Given this list of marker genes ARRDC4, INPP4B, MFAP1, TOR4A, RFXANK, TEX35, ABCC4, PRDM16, PSME2, USP18, TIGD2, PEX7, ARMC7, DMD, C16orf54, CD82, F2R, RLIG1, IFT57, RIC8A, TRAF5, COL1A2, AVEN, CA3, VAMP8, UFSP1, CHMP2A, STAB1, NOTCH1, LAMA5, PTPN9, CRYL1, SOCS2, CST7, LPCAT1, NUDT18, FARP2, CASTOR1, ZC2HC1A, RNF216, CHAC1, NENF, EEF1AKMT1, TM7SF3, RFTN2, ELL2, HSD17B11, PTF1A, GPR15, TSACC, STPG1, CLDN12, PRG4, STING1, NUCB2, EXOC3, KLK8 (kallikrein related peptidase 8), ITGAE, GRN, NFE2L1, ECH1, TESC, IRAK4, NFIX, SLX9, SEMA4B, SYT11, VAMP5, NT5E, ATXN1, KMT5A, TOMM40L, NAB1, WWP1, HOMER1, ALDH2, RNH1, MVB12A, IKZF5, ZDHHC2, ATM, TBC1D30, NPC2 (NPC intracellular cholesterol transporter 2), SLC15A3, TUFT1, LIPT1, MAF, SNX9, SEMA4F (NCBI Gene Id 9408), MLX, CCDC22, CCR5, CRMP1, SAPCD1, FGL2, TXNIP, SLA2, GPR18, RRAGD, NCF4, FCRL1, S100A11, SPSB1 (splA/ryanodine receptor domain and SOCS box containing 1), C1QTNF12, PMEPA1, CHST12, TBXA2R, FAM234A, ASS1, ATP6V1E1, GZMB, BAAT, EFCAB7, CYP39A1, SIAH1, TAF9B, RNASE4, ARL5A, GM2A, MTHFD2, DRC1, IFIT1, VPS28, IFITM2, CNP, AQP3, XPO4, IL6R, LIG4, DERL1, SH3BP5, KLF15, TRIB1, CAPG, FBXL4, IL1R2, RNF43, BATF, CD52, S100A6, ZSCAN12 (zinc finger and SCAN domain containing 12), TOE1, KLRG1, HS1BP3, NICN1, MANSC1, NRN1, TMEM102, NR1D1, DHRS7B, PTGER4, HOPX, RBM11 (NCBI Gene Id 54033), S1PR4, CALHM2 (calcium homeostasis modulator family member 2), CMTM7, JAZF1, TIAM1, CKLF, DIPK1A, ANXA11, B3GALT4, C15orf48, EBI3, NIBAN2, ING3, NDRG1, RNF19B, TDRP (NCBI Gene Id 157695), NDRG4, C15orf61 (NCBI Gene Id 145853), TMIE, TMPRSS2, CSRP2, DDX59, CRIP1, AXL, PROS1, VRK1, HLA-DMA, LRRC61, ECI1, CAPN2, FXYD5, TAF5L, SHC1, NOXRED1, CERS4, FBXL14, CCL5, RPL17, KCNE3, DHRS7, SYNGR2, GPR75, CHRNA5, MARVELD1, SEMA4D, FAM210B, CCR6, here is a description of the gene set: studied in species Homo sapiens from publication Fu W, Ergun A, Lu T, Hill JA, Haxhinasto S, Fassett MS, Gazit R, Adoro S, Glimcher L, Chan S, Kastner P, Rossi D, Collins JJ, Mathis D, Benoist C (PMID 22961053) Genes up-regulated in CD4 T conv over-expressing: FOXP3 versus LEF1 and FOXP3. The transcription factor FoxP3 partakes dominantly in the specification and function of FoxP3+ CD4+ T regulatory cells (Tregs), but is neither strictly necessary nor sufficient to determine the characteristic Treg transcriptional signature. Computational network inference and experimental testing assessed the contribution of several other transcription factors (TFs). Enforced expression of Helios or Xbp1 elicited specific signatures, but Eos, Irf4, Satb1, Lef1 and Gata1 elicited exactly the same outcome, synergizing with FoxP3 to activate most of the Treg signature, including key TFs, and enhancing FoxP3 occupancy at its genomic targets. Conversely, the Treg signature was robust to inactivation of any single cofactor. A redundant genetic switch thus locks-in the Treg phenotype, a model which accounts for several aspects of Treg physiology, differentiation and stability. Human Gene Set: GSE40274_FOXP3_VS_FOXP3_AND_LEF1_TRANSDUCED_ACTIVATED_CD4_TCELL_UP